The following is a description of a gene set: Human Gene Set: GOBP_DISTAL_CONVOLUTED_TUBULE_DEVELOPMENT species: Homo sapiens The process whose specific outcome is the progression of the distal convoluted tubule over time, from its formation to the mature structure. The distal convoluted tubule is the first segment of the nephron lying just downstream from the loop of Henle, immediately after the macula densa. Among other functions, in humans it is responsible for the reabsorption of about 5% of filtered sodium via the thiazide-sensitive Na-Cl symporter., and this is the list of marker genes: CALB1, PAX2, UMOD, PAX8, POU3F3